Given this list of marker genes CHM, ZDHHC23, ITGAM, TCAF2, ZDHHC18, SSR1, YIF1B, ZDHHC6, RAB3IP, ITGB2, ZFAND2B, SSR2 (signal sequence receptor subunit 2), SRP9, LARGE1, SSR3 (signal sequence receptor subunit 3), ZDHHC4, ZDHHC14, TRAM1, GJD2-DT (GJD2 divergent transcript), AKT2, RABGEF1, SEC63, BHLHE40-AS1, PDZK1, AQP11, RTP2, SEC61G, USP17L2, SGTA, SEC61B, SRP14, RTP1, INPP5K, ADORA1, RN7SL3, PIKFYVE, ZDHHC7, SRP54, ZDHHC24, SNAP25-AS1, SDCBP, MYO1C, ZDHHC15, BAG6, PRKCI, ARL6, GET4, CDK5R1, SEC61A1, ANKRD13C, SEC61A2, VPS37C, RTP5, ZDHHC11, GOLGA7, ATG3, CHMP4A, TAOK2, MTCL1, NACA4P, CIB1, SRPRA, SIL1, SEC62, RN7SL2, ICMT, CHMP4B, DMTN, VPS37A, ZDHHC22, TRAM1L1, ZDHHC20, RTP3, STOM (stomatin), ZDHHC12, VPS37D, ZDHHC3, GLP1R, NACAD, ZDHHC1, ERBB2, TRAM2, UBL4A (NCBI Gene Id 8266), PARD3, ZDHHC9, PAK1, SRPRB, KCNE1, ENSG00000283175, ZDHHC21, ZDHHC2, SRP72, ANK3, RTP4, SLC51B, ARL6IP1, SGTB, FYN, CEMIP, CDK5, SRP68 (NCBI Gene Id 96239), TCAF1, MIEF2, NCF1, ITGB1BP1, SRP19, ZDHHC19, GDI1, VPS37B, HSPA5, RN7SL1, SLC1A1 (NCBI Gene Id 6505), CHP1, HPCA, MIEF1, GOLGA7B, CWH43, KCNB1, TTC9-DT, HRAS, NACA2 (nascent polypeptide associated complex subunit alpha 2), ZDHHC11B, NACA, CACNG2, GET1, PRNP, C2CD5, MICALL1, here is a description of the gene set: The process of directing proteins towards a membrane, usually using signals contained within the protein. Human Gene Set: GOBP_PROTEIN_TARGETING_TO_MEMBRANE species: Homo sapiens